Given this list of marker genes CACNG8, GRIP2, CAMK2B, GRIP1, AP2A1, DLG4 (discs large MAGUK scaffold protein 4), AP2A2, GRIA4, PRKCA, CAMK2G, GRIA2 (NCBI Gene Id 2891), TSPAN7, MDM2, NSF, AP2S1, DLG1, CAMK2D, CACNG2, GRIA1, PRKCB, AKAP5, PICK1, AP2M1, CAMK2A, CACNG3, AP2B1, MYO6, CACNG4, PRKCG, GRIA3, EPB41L1, here is a description of the gene set: part of: Glutamate binding, activation of AMPA receptors and synaptic plasticity Repetitive presynaptic activity causes long lasting changes in the postsynaptic transmission by changing the type and the number of AMPA receptors. These changes are brought about by trafficking mechanisms that are mainly controlled by activity dependent phosphorylation/desphosphorylation of the GluR1/GluR2 subunits. studied in species Homo sapiens Reactome Pathway: Trafficking of AMPA receptors